The following is a description of a gene set: Human Gene Set: REACTOME_CHONDROITIN_SULFATE_DERMATAN_SULFATE_METABOLISM Chondroitin sulfate/dermatan sulfate metabolism species: Homo sapiens, and this is the list of marker genes: GPC5, SDC2, GPC2, DSE, UXS1, SDC4, UST, CHST15, BCAN, CHST12, AGRN, VCAN, GPC4, CHST9, CHPF2, CHST7, XYLT2, B3GAT2, BGN, SDC3, CHSY3, CHST11, SDC1, DCN, GPC3, CSPG4, HEXB, HSPG2, CSPG5, IDS, CHST3, B3GAT3, HYAL3, CSGALNACT2, DSEL, IDUA, CHST14, ARSB, CHPF, HYAL1, CHST13, CSGALNACT1, CHSY1, HEXA, XYLT1, GPC1, B3GALT6, B4GALT7, GPC6, NCAN, B3GAT1